Given this list of marker genes PPP2CB, GSK3B, PPP2R5C, PPP2R5D, PPP2CA (protein phosphatase 2 catalytic subunit alpha), PPP2R1B, CSNK1A1 (casein kinase 1 alpha 1), AMER1 (APC membrane recruitment protein 1), PPP2R5A, PPP2R5E, APC, PPP2R1A, PPP2R5B, AXIN1, here is a description of the gene set: species: Homo sapiens AMER1/WTX is a component of the destruction complex that interacts directly with beta-catenin through its C-terminal half. Depletion of AMER1 through siRNA stabilizes cellular beta-catenin levels and increases transcriptional activity in a reporter assay consistent with a role for AMER1 in the degradation of beta-catenin. Deletions of the entire AMER1 gene have been reported in Wilms tumor, as have nonsense and missense mutations that truncate the protein before the beta-catenin interaction domain. These mutations are predicted to stabilize beta-catenin and increase WNT signaling. part of: Signaling by WNT in cancer Reactome Pathway: Signaling by AMER1 mutants